Given this list of marker genes GYG1, GYS1, here is a description of the gene set: species: Homo sapiens Reactome Pathway: Glycogen storage disease type XV (GYG1) part of: Glycogen storage diseases Glycogen synthesis is normally initiated by the autoglycosylation of glycogenin (GYG) to form oligo (1,4)-alpha-D-glucosyl GYG. A missense mutation of GYG1 yields a protein that cannot undergo glucosylation, leading to failure of glycogen synthesis, associated with muscle weakness and other abnormalities.